The following is a description of a gene set: Mouse Gene Set: CUI_TREG_BAFF_RESPONSE_DN studied in species Mus musculus Cytokines mediate cell-cell communication in the immune system and represent important therapeutic targets. A myriad of studies have highlighted their central role in immune function, yet we lack a global view of the cellular responses of each immune cell type to each cytokine. To address this gap, the authors created the Immune Dictionary, a compendium of single-cell transcriptomic profiles of more than 17 immune cell types in response to each of 86 cytokines (>1,400 cytokine-cell type combinations) in mouse lymph nodes in vivo. A cytokine-centric view of the dictionary revealed that most cytokines induce highly cell-type-specific responses. For example, the inflammatory cytokine interleukin-1β induces distinct gene programmes in almost every cell type. A cell-type-centric view of the dictionary identified more than 66 cytokine-driven cellular polarization states across immune cell types, including previously uncharacterized states such as an interleukin-18-induced polyfunctional natural killer cell state. Genes negatively differentially expressed in cell type: Treg upon treatment with cytokine: BAFF in mouse lymph nodes in vivo. from publication Cui A, Huang T, Li S, Ma A, Pérez JL, Sander C, Keskin DB, Wu CJ, Fraenkel E, Hacohen N (PMID 38057668), and this is the list of marker genes: Jun, Junb, Hspa1a, Fos, Klf6, Dnaja1, Dusp1 (NCBI Gene Id 98098), Hspa1b, Rgs2